Given this list of marker genes Umod, Avpr1a, Aqp2, Sipa1, Nfat5, Lrp11, here is a description of the gene set: studied in species Mus musculus Mouse Gene Set: GOBP_RESPONSE_TO_WATER_DEPRIVATION Any process that results in a change in state or activity of a cell or an organism (in terms of movement, secretion, enzyme production, gene expression, etc.) as a result of a water deprivation stimulus, prolonged deprivation of water.